Given this list of marker genes SHMT2, SEC31A, H2AC6, USP3, ZNF451, NUCB2, UBR4, YY1AP1, ASNS, HERPUD1, ZRANB2, MYC, RPS2, TGFB3, SERINC1, RAB5A, VEGFA, SLC3A2, PNISR, FNTA, MCCC1, KCMF1, ZFP36L1, IPO7, TFRC, IMPA1, EXOC2, CENPL, NEAT1, FTMT, CDKN1B, CPEB4, here is a description of the gene set: Genes up-regulated in EVSA-T cells (breast cancer) treated THC (delta-9-tetrahydrocannabinol). from publication Caffarel MM, Moreno-Bueno G, Cerutti C, Palacios J, Guzman M, Mechta-Grigoriou F, Sanchez C (PMID 18454173) It has been recently shown that cannabinoids, the active components of marijuana and their derivatives, inhibit cell cycle progression of human breast cancer cells. Here we studied the mechanism of Delta(9)-tetrahydrocannabinol (THC) antiproliferative action in these cells, and show that it involves the modulation of JunD, a member of the AP-1 transcription factor family. THC activates JunD both by upregulating gene expression and by translocating the protein to the nuclear compartment, and these events are accompanied by a decrease in cell proliferation. Of interest, neither JunD activation nor proliferation inhibition was observed in human non-tumour mammary epithelial cells exposed to THC. We confirmed the importance of JunD in THC action by RNA interference and genetic ablation. Thus, in both JunD-silenced human breast cancer cells and JunD knockout mice-derived immortalized fibroblasts, the antiproliferative effect exerted by THC was significantly diminished. Gene array and siRNA experiments support that the cyclin-dependent kinase inhibitor p27 and the tumour suppressor gene testin are candidate JunD targets in cannabinoid action. In addition, our data suggest that the stress-regulated protein p8 participates in THC antiproliferative action in a JunD-independent manner. In summary, this is the first report showing not only that cannabinoids regulate JunD but, more generally, that JunD activation reduces the proliferation of cancer cells, which points to a new target to inhibit breast cancer progression. Human Gene Set: CAFFAREL_RESPONSE_TO_THC_UP species: Homo sapiens